The following is a description of a gene set: Genes down-regulated in spleen B lymphocytes with IRF8 knockout: marginal zone versus follicular. from publication Feng J, Wang H, Shin DM, Masiuk M, Qi CF, Morse HC 3rd (PMID 21178004) species: Homo sapiens Conditional IRF8 KO mice (mice with a conditional allele of Irf8 crossed with CD19-Cre mice) showed increased numbers of both Gene expression data spleen marginal zone (MZ) and Gene expression data spleen follicular (FO) B cells compared to control mice. To evaluate gene expression patterns that distinguished FO or MZ B cells derived from conditional KO and control mice, we used Affymetrix GeneChip® Mouse gene 1.0 ST Array. Human Gene Set: GSE24972_MARGINAL_ZONE_BCELL_VS_FOLLICULAR_BCELL_IRF8_KO_DN, and this is the list of marker genes: C19orf81, ODAD4, UROC1, RMND1, PEX13, KAT8, STK36, MEFV, KIAA0040, PLEKHF1, ZNF703, C1orf52, TIGD2, DNAJC18, PTGER2, RNF34, ELMOD2, SCML4, SERPINE1, MT2A, AP1B1, SELP, GOLGA7B, ATG9A, MT3, IFT25, RPP30, TAGLN3, SASH1, SLC49A4, TMOD1, RNASE4, KLHL24, ZC3H11A, PICALM, ARF4, ZFYVE28, NPY4R, DNAH12, MGAT4A (alpha-1,3-mannosyl-glycoprotein 4-beta-N-acetylglucosaminyltransferase A), ITGA2B, NIPAL1 (NIPA like domain containing 1), FCGRT, SNX16, DSTN, WASHC2A, SPAG4, SLC17A1, PITX1, TNS1, ZBTB39, DUSP1, POP5, CFAP68, MMP10, APAF1, TMEM9, BAG1, PPM1E, FKBP5, ATL2, HERPUD1, ADAM2, LIPG (lipase G, endothelial type), CTLA4, EXT1, TMEM107, FAM210B, MYO7B, MIS18A, SLC13A3, TFAP2E, PLCD3, SRD5A1, GHRHR, YPEL5, AUH, MIDEAS, ADAP2, KIAA0319, CTDSP1, H3-5, ICOSLG, GSR (glutathione-disulfide reductase), ADGRV1, FOXH1, TMEM247, SLC4A8, CTNND1, MESD, ITGA5, CD38, CIDEA, MIPOL1, BBX, ECI2, STX11, IFT57, PMP22, CCL19, PLCB4, BCL7C, GDAP2, PEAK1, FILIP1L, CNRIP1, PAOX, KLHL7, PLA1A, IL18, ORM2, CLIC6, B3GALNT1, PIGB, CYP2J2, MYO10, LMF1, TRPV4, B4GALT1, CTSB, IQGAP2, THBD, CLUAP1, QRFPR (NCBI Gene Id 84109), SLFN13, OVOL1, GNG2, ITLN1, EPHX4, CCNB1IP1, DCAF12, SPDEF, TNFSF4, GPAT3, NOTCH4, TMEM174, A4GNT, BRCC3, HMGA2, FBXO22, ALG1, CNOT8 (NCBI Gene Id 9337), KDF1, HEPHL1, GATM, CHKA, CFAP298, PATL2, PHYHD1, DOCK4, RTRAF, NDRG1, ATF7IP2, VAX1, HARBI1, FRMD4B, CCPG1, DNAJA3, ABCA6, CABP5, CEP104, IRF2BPL (NCBI Gene Id 64207), KAZN, C1orf50, NBN, CHP2, NOS1, GPR180, RHOD, TSNAX, NTN5, PTGDR, TCTN3, CPSF7, DAB2, PCCA, NMRK1, WDR44, FADS6, ITGB7, WNT7B, KCTD5, ADRA1A, ALPK1, FBXO36, HMGB1, RNASE2, TENT5A, NR1I2, RNF103, DNAAF8, SERPINB1, PRKAR2A, RPAIN, MAF, LAMTOR3, MDM4, NELFCD, PHYH